Given this list of marker genes PRF1, TIMP1, DCN, CCNA1 (NCBI Gene Id 8900), PDCD4, MMP2, CFLAR, EMP1, IGFBP6, GNA15, LEF1, ROCK1, IL18, H1-0, BNIP3L, EREG, CCND2, PSEN2, KRT18, BRCA1, RNASEL, RARA, PPT1, BIK, CCND1, GADD45A, BAX, PMAIP1, SQSTM1, IFNB1, CASP8, BID, BCL2L11, FDXR, RETSAT, DNM1L, PTK2, IL1A, CASP4, PSEN1, PDGFRB, HMGB2, SLC20A1, SMAD7, ANKH, HGF, APP, GPX1, DDIT3, PPP2R5B, BCL2L10, GSTM1, DNAJA1, CASP3, RELA, CDK2, CD38, CASP7, GPX4 (glutathione peroxidase 4), BTG2, TIMP2, TIMP3, PPP3R1, CTH, GSN, TAP1, CD14, GPX3, NEFH, FASLG, IFITM3, SC5D, BIRC3, FAS, CASP6, LGALS3, PEA15 (proliferation and apoptosis adaptor protein 15), IRF1, SOD2, BCL2L1, BMP2, CASP9, HMOX1, WEE1, GUCY2D, TNFRSF12A, PAK1, EBP, SOD1, CD2, TGFBR3, FEZ1, CD44, ISG20, MGMT, LUM, DNAJC3, PLPPR4 (phospholipid phosphatase related 4), CASP1, TNFSF10, GADD45B, TOP2A, MADD, CDKN1A, TNF, DIABLO, CD69, HSPB1, BCL10, ERBB3, CLU, ERBB2, CTNNB1, DPYD, PLAT, ANXA1, TGFB2, NEDD9, GSR, TSPO (translocator protein), AIFM3, CREBBP (CREB binding protein), F2R, SATB1, ENO2, MCL1, BCL2L2, ADD1, JUN, IFNGR1, ETF1, CASP2, VDAC2, EGR3, ATF3, CYLD, PLCB2, AVPR1A, RHOB, RHOT2, SAT1, IER3, BTG3, DFFA, IL1B (interleukin 1 beta, NCBI Gene Id 3553), SPTAN1, XIAP, CDC25B, BMF, GCH1, BCAP31, BGN, TXNIP, CDKN1B, DAP, DAP3, IGF2R, CAV1, F2, LMNA, IL6, here is a description of the gene set: species: Homo sapiens from publication Liberzon A, Birger C, Thorvaldsdóttir H, Ghandi M, Mesirov JP, Tamayo P (PMID 26771021) Genes mediating programmed cell death (apoptosis) by activation of caspases. Human Gene Set: HALLMARK_APOPTOSIS